The following is a description of a gene set: from publication Cao J, O'Day DR, Pliner HA, Kingsley PD, Deng M, Daza RM, Zager MA, Aldinger KA, Blecher-Gonen R, Zhang F, Spielmann M, Palis J, Doherty D, Steemers FJ, Glass IA, Trapnell C, Shendure J (PMID 33184181) species: Homo sapiens Marker genes curated from the annotated cluster as represented in the Descartes Human Gene Expression During Development database. The gene expression program underlying the specification of human cell types is of fundamental interest. The study authors generated human cell atlases of gene expression and chromatin accessibility in fetal tissues. For gene expression, the study authors applied three-level combinatorial indexing to >110 samples representing 15 organs, ultimately profiling ~4 million single cells. The study authors leveraged the literature and other atlases to identify and annotate hundreds of cell types and subtypes, both within and across tissues. Our analyses focused on organ-specific specializations of broadly distributed cell types (such as blood, endothelial, and epithelial), sites of fetal erythropoiesis (which notably included the adrenal gland), and integration with mouse developmental atlases (such as conserved specification of blood cells). These data represent a rich resource for the exploration of in vivo human gene expression in diverse tissues and cell types. Human Gene Set: DESCARTES_FETAL_HEART_SMOOTH_MUSCLE_CELLS, and this is the list of marker genes: PDGFRB (platelet derived growth factor receptor beta), RGS5-AS1 (NCBI Gene Id 101928404), NOTCH3, BCAS3-AS1, LMOD1 (NCBI Gene Id 25802), CCDC190, KCNJ8, OR51E1, TMEM74B, SEMA5B, FOXS1, ABCC9, ARHGEF17, MDFIC2, CYGB, ADRA1D, FOXL1, SEPTIN4-AS1, ERRFI1-DT, PELO-AS1, CARMN, AGT, HIGD1B, MYH11, TBX2-AS1, PDE4C, LGR6 (leucine rich repeat containing G protein-coupled receptor 6), MYO3A, THBS4, NDUFA4L2, PLA2G5, APOL5, ACTA2, ENPEP, HCG22, LINC02237, ACTA2-AS1, COX4I2, ILDR1, AOC3, TAGLN, CACNA1S, SULT1E1, KCNAB1, RGS16, C11orf96, ACTG2, GPR20